The following is a description of a gene set: from publication Cao J, O'Day DR, Pliner HA, Kingsley PD, Deng M, Daza RM, Zager MA, Aldinger KA, Blecher-Gonen R, Zhang F, Spielmann M, Palis J, Doherty D, Steemers FJ, Glass IA, Trapnell C, Shendure J (PMID 33184181) The gene expression program underlying the specification of human cell types is of fundamental interest. The study authors generated human cell atlases of gene expression and chromatin accessibility in fetal tissues. For gene expression, the study authors applied three-level combinatorial indexing to >110 samples representing 15 organs, ultimately profiling ~4 million single cells. The study authors leveraged the literature and other atlases to identify and annotate hundreds of cell types and subtypes, both within and across tissues. Our analyses focused on organ-specific specializations of broadly distributed cell types (such as blood, endothelial, and epithelial), sites of fetal erythropoiesis (which notably included the adrenal gland), and integration with mouse developmental atlases (such as conserved specification of blood cells). These data represent a rich resource for the exploration of in vivo human gene expression in diverse tissues and cell types. Marker genes curated from the annotated cluster as represented in the Descartes Human Gene Expression During Development database. Human Gene Set: DESCARTES_FETAL_ADRENAL_VASCULAR_ENDOTHELIAL_CELLS studied in species Homo sapiens, and this is the list of marker genes: EEIG1, CLEC14A, ECSCR, SMIM9 (small integral membrane protein 9), GPM6A, MMRN2, CIMAP1D, NRN1 (neuritin 1), ROBO4, RGS7BP, GPR182, SEMA6B, CEACAM1, HLX, EEF1A1P31 (eukaryotic translation elongation factor 1 alpha 1 pseudogene 31), ARHGAP29, NPR1, ENSG00000253348, CCDC60, CD300LG, GALNT14, TMEM235 (NCBI Gene Id 283999), OIT3, CALCRL, ELK3, SLC5A4, TERLR1, SPAAR, BTNL8, EDN1, ENSG00000255462, PCAT19, CMKLR2, LINC03002, ESM1, NHERF2, EFNA1, HID1-AS1, CRHBP, SOX7-AS1, MADCAM1, TEK, FCGR2B, CHRM3, ID1, CDA, RN7SL169P, USHBP1, ROPN1L, TIE1, RAET1G, STC2, RBP5, ENG, CYP26B1, SOX18, NAT8, MYRIP, TRPM6, RAET1E, NOTCH4, ADGRL4, BCL6B, HRCT1 (NCBI Gene Id 650695), LRRC70, LINC00305, EFNB2, FFAR2, PDE2A, TMEM88, SOX17, ACVRL1, PCDH12, APLNR, HYAL2, LINC02005, RAMP2, KDR, ENSG00000272789, ADCY4 (adenylate cyclase 4), AFAP1L1, CX3CL1, TMEM233, TM4SF18, LINC02289, CNTNAP3B, CP (NCBI Gene Id 1356), PODXL, PLVAP, FGF23 (fibroblast growth factor 23), SOX7 (NCBI Gene Id 83595), KANK3, DNASE1L3, FMO6P, IRX5, GRAPL, EFCC1, RASIP1, NT5ELP, EHD3, SLC26A5, THSD1, PLIN4, PLPP3, SNCAIP, SHANK3, FLT4, ENSG00000248636, ENSG00000253177, ACSM2B, FCN2, DLL4 (NCBI Gene Id 54567), GPR4, ENSG00000233251 (novel transcript, antisense to CCDC85A), CDH13, F8, VAMP5, LINC02196, INHBB, SLCO2A1, FAM110D (NCBI Gene Id 79927), ARHGEF15, CDH5, TACR1, EXOC3L1, RIPPLY3, TCIM, STAB2, SCGB3A1, SHE, TM4SF18-AS1, BTNL9, CA4, GALNT15, PTPRB, LDB2, FCN3, ST6GALNAC3, DIPK2B, CLDN5, CD34, IGFBP1, NR5A2, TMEM255B, IRX3